Given this list of marker genes FHL1, CD24, UCK2, MAPK12, COL7A1, DBNL, BMP6, MGP, TRIB3, NNAT, CDKN2B, MTHFD2, CH25H, BPGM, TCF7, CARS1 (cysteinyl-tRNA synthetase 1), DDX47, GLRB, CCN4, EFNB2, ADORA2B, GJB3, RNF227, PRSS23, CRABP2, RHOU, DLK1, PTPRF, NDN, WNT10A, here is a description of the gene set: from publication Tseng YH, Butte AJ, Kokkotou E, Yechoor VK, Taniguchi CM, Kriauciunas KM, Cypess AM, Niinobe M, Yoshikawa K, Patti ME, Kahn CR (PMID 15895078) Human Gene Set: TSENG_ADIPOGENIC_POTENTIAL_UP The insulin/IGF-1 (insulin-like growth factor 1) signalling pathway promotes adipocyte differentiation via complex signalling networks. Here, using microarray analysis of brown preadipocytes that are derived from wild-type and insulin receptor substrate (Irs) knockout animals that exhibit progressively impaired differentiation, we define genes/expressed-sequence tags whose expression in preadipocytes correlates with the ultimate ability of the cells to differentiate. Many of these genes, including preadipocyte factor-1 (Pref-1) and multiple members of the Wnt signalling pathway, are related to early adipogenic events. Necdin is also markedly increased in Irs knockout cells that cannot differentiate, and knockdown of necdin restores brown adipogenesis with downregulation of Pref-1 and Wnt10a expression. Insulin receptor substrate proteins regulate a necdin-E2F4 interaction that represses peroxisome-proliferator-activated receptor gamma (PPARgamma) transcription via a cyclic AMP response element binding protein (CREB)-dependent pathway. Together these define a key signalling network that is involved in brown preadipocyte determination. Genes showing increasing expression in brown preadipocytes with decreasing ability of the cells to differentiate. studied in species Mus musculus